The following is a description of a gene set: Mouse Gene Set: WP_MIR127_IN_MESENDODERM_DIFFERENTIATION miR-127 in mesendoderm differentiation species: Mus musculus, and this is the list of marker genes: T, Mir127, Smad2, Acvr1, Acvr2a, Cfc1, Foxa2, Nodal, Smad4, Lefty2